The following is a description of a gene set: Human Gene Set: GOBP_CARDIAC_PACEMAKER_CELL_DIFFERENTIATION studied in species Homo sapiens The process in which a relatively unspecialized cell acquires specialized features of a pacemaker cell. Pacemaker cells are specialized cardiomyocytes that are responsible for regulating the timing of heart contractions., and this is the list of marker genes: SHOX2, BVES, MESP1, MAML1, ISL1, KCNJ8, TBX3, TBX5, BMPR1A, NKX2-5, TBX18